Given this list of marker genes Ncbp1, Ncbp2 (NCBI Gene Id 98015), Srsf1, Polr2l, Sf3b5, Snrnp35, Snrpf, Sf3b3, Zcrb1, Zrsr2, Txnl4a, Snrnp40, Eftud2, Polr2f, Prpf6, Snrnp25, Rnpc3, Snrpd1, Sf3b4, Polr2c, Polr2h, Polr2g, Ddx42, Polr2a, Snrnp200, Snrpe, Snrpd2, Polr2k, Ddx23, Srsf2, Sf3b1, Polr2i, Pdcd7, Gtf2f1, Polr2b, Zmat5, Gtf2f2, Snrpd3, Sf3b2 (splicing factor 3b, subunit 2), Snrpg, Srsf7 (NCBI Gene Id 60426), Polr2d, Ybx1, Snrpb, Snrnp48, Prpf8, Polr2e, here is a description of the gene set: mRNA Splicing - Minor Pathway species: Mus musculus Mouse Gene Set: REACTOME_MRNA_SPLICING_MINOR_PATHWAY